The following is a description of a gene set: A mitotic cell cycle process comprising the steps by which the nucleus of a eukaryotic cell divides; the process involves condensation of chromosomal DNA into a highly compacted form. Canonically, mitosis produces two daughter nuclei whose chromosome complement is identical to that of the mother cell. species: Homo sapiens Human Gene Set: GOBP_MITOTIC_NUCLEAR_DIVISION, and this is the list of marker genes: CHEK2, AURKC, KIF3B, KPNB1, TUBG1, CDK1 (cyclin dependent kinase 1), PDGFB, RIPOR2, MAD2L1, SMC4, ANAPC11, TTN, NSL1, MIS12, PLK1, KIFC1, RGCC, REEP3, CEP85, RHOA, TOM1L2, BECN1, HNRNPU, SMC1A, LCMT1, AURKAIP1, APC, DRG1, HOXA13, IGF1, MTBP, EML3, CHMP4B, BROX, SKA2, CDKN1B, BOD1, PDCD6IP, SIRT1, BUB1B (BUB1 mitotic checkpoint serine/threonine kinase B), EPS8, CCDC66, NEUROG1, KIF25, RPL24, TOM1L1, BAZ1B, SPHK1, KIF20B (NCBI Gene Id 9585), BIRC5, FBXW5, USP16, INO80, PHIP, CENPI, NSFL1C, NSMCE2, AAAS, CUL3, ZWILCH, FGF8, UBE2C, KIF11, NME6, SKA3, STAG1, MAD2L2, WRAP73, WAPL, IL1B, ANAPC5, CHMP1B, CDCA8, SPICE1, KIF2C, KNTC1, CDCA5, CHMP7, CHMP2A (NCBI Gene Id 27243), NUSAP1, MAPRE1, PDXP, CHMP4BP1, VPS4B, CDC14A, TGFA, AURKA, MAD2L1BP, HSPA1A, CAV2, CHMP2B, NFE2L1, RAN, SPAST, CCDC61, ATM, TPR, GOLGA2, PRICKLE1, AURKB, PRAP1, CDC23, ARHGEF10 (Rho guanine nucleotide exchange factor 10), KATNB1, BUB3, KMT5A, BORA, NCAPD2, PIN1, KIF4A, XRCC3, CUL7, CDC16, BMP4, PRMT5, EREG, INSR, TENT4A, AKAP8L, ANLN, KAT2B, TTK, CDC20, EDN3, CENPC, NCAPH, ESPL1, SPC25, NCAPH2, AKAP8, EDN1, BCCIP, CCNB1, BMP7, EGF, DUSP1, CCSAP, CDC14B, NFIA, MAP10 (NCBI Gene Id 54627), KIF14, CEP55, CDK5RAP2, KIF23, KNL1, NCAPD3, MYBL2, SIRT2, MAP9, TGFB1 (NCBI Gene Id 7040), PSRC1 (proline and serine rich coiled-coil 1), RANGRF, PPP1CC, ZW10, CEP97, CDC14C, RCC1, GEN1, PIBF1, SPAG5, TNF, ABRAXAS1, CLASP2, ANKLE2, NDE1, POLDIP2, PPP2R1A, RB1, HASPIN, STAG2, CEP192, CHMP6, SEH1L, SH2B1, KIF2A, KIF4B, PHF13, MKI67, INS, NPM2, NIPBL, CHEK1, UBE2I, SMC3 (structural maintenance of chromosomes 3), CENPE, SPDL1, ZWINT, NUDC, CHMP1A, DRD3, CUL9, CDKN1C, NUF2, TRIP13, SPC24, DIS3L2, DCTN2, KNSTRN, PRP4K, CDC25C, NCAPG2, RACGAP1, ANAPC15, OFD1, KIF18A, ABRAXAS2, PPP1R9B, FLNA, H2BW1, CDT1, REEP4, PSMG2, MAD1L1, SMARCA5, OBSL1, DAPK3, LRP5, CTDP1, CDC42, KIF22, IL1A, SKA1, SMC2, CCDC8, FBXO43, INCENP, CHMP4C, NDC80, TUBG2, PDGFRB, CENPK, KIF15, RAD21, HSPA1B, ANKRD53, CHMP3 (charged multivesicular body protein 3), NFIB, BANF1, NDEL1, KLHL22, NCAPG, KIF18B, SMPD3 (NCBI Gene Id 79756), KLHDC8B, BTC, ZNF207, PKMYT1, RAB11A, EML4, PINX1, PRC1, RRS1, NUMA1, BUB1, DYNC1LI1, FBXO5, UBXN2B, EPGN, L3MBTL1, CDCA2, CHAMP1, DMRT1, ANAPC7, CHMP4A, CHMP5, TEX14, TPX2, CLASP1, LSM14A, RMDN1, UHRF1, CENPF, USP44, NUP62, IK, MZT1, MISP, VPS4A, DLGAP5, CD28, IGF2, KAT5, RANBP1, UBE2S, NEK2, PPP2R2D